The following is a description of a gene set: from publication Chen Y, Wang X (PMID 31504780) Mouse Gene Set: MIR_7224_3P studied in species Mus musculus Genes predicted to be targets of miRBase v22 microRNA mmu_miR_7224_3p in miRDB v6.0 with MirTarget v4 prediction scores > 80 (high confidence targets)., and this is the list of marker genes: Art4, Spp1, Mgst1, Cenpi, Igf1r, Sema3a, Clec10a, Slc11a2, Cnot6, Mex3c, Elf2, Gna15, Adam23, Nfia, Eef1a1, Rundc3b, Med22 (mediator complex subunit 22), Pold3, Srgap1, Zbtb41, Camta1, Tex11, Ankrd13c, Prr36, Scamp1, Rbms3, Lrp6, Syt14, Rd3, Atp6v1e1, Zfp141, Rnf145, Slc25a15, Ptpn20, Ltbp1, Sorbs1, Ccdc59, Nup160, Oprl1, Wiz, Arhgap6, Atxn2, Syt15, Dio2, Adam2, Nampt, F9, Txndc5, Casd1, Cnksr3, Fgf16, Mapk8, Mospd1, Gid4, Fkbp9, Slc9a5, Sel1l, Caprin1, Ppp4r2, Ostc, Rsph4a, Nipa1, Rab2a, Rock1, Fli1, Arid2, Synj2bp, Zfp668, Rbm3, Lrrc51, Commd3, Alox5, Tfcp2l1, Rad17, Neb, Arid4a, Basp1, 4921517D22Rik, Ttc7b, Cep135